Given this list of marker genes ZNF781, RGCC, HBG2, FTH1 (ferritin heavy chain 1), ZDHHC24, DNAJC12, MIR614, CHI3L1, PLAT, H2BC12, FIBIN, ENSG00000254531, REX1BD, SERPINA3, C6orf226, A1BG, ATP5F1D, FMOD, SCN7A, PNMA2, SLC39A4, CFD, RGS18, DDT, CHCHD2, SELENOP, HSD11B1, SYNPO2, HSD17B2, GPRC5A, HLA-A, PDGFD, CYTL1, TMEM176A, ADH1B, PTGDS, APOE, here is a description of the gene set: studied in species Homo sapiens Genes down-regulated in MERS-CoV infection (MRC5 cells, MOI: 3, 24hpi) Human Gene Set: BLANCO_MELO_MERS_COV_INFECTION_MCR5_CELLS_DN from publication Blanco-Melo D, Nilsson-Payant BE, Liu WC, Uhl S, Hoagland D, Møller R, Jordan TX, Oishi K, Panis M, Sachs D, Wang TT, Schwartz RE, Lim JK, Albrecht RA, tenOever BR (PMID 32416070) Analysis of the transcriptional response to SARS-CoV-2 compared with other respiratory viruses, including MERS-CoV, SARS-CoV-1 (SARS), human parainfluenza virus 3 (HPIV3), respiratory syncytial virus (RSV), and IAV.